Given this list of marker genes AGO4, MIR451A, CDH11, TNRC6A, AGO3, MIR200C, TNRC6B, TNRC6C, AGO1, AGO2, MOV10, here is a description of the gene set: Several microRNAs are implicated in posttranscriptional regulation of CDH11 gene expression. The diagram only shows microRNAs reported to downregulate CDH11 mRNA and/or protein levels by at least 2 studies, with at least one study providing human evidence, and at least one study providing mechanistic evidence in the form of luciferase reporter assay and/or formation of the microRNA-mRNA complex. For a more detailed description of criteria for microRNA annotation please refer to Huntely et al. 2016.<br><br>The following CDH11-targeting microRNAs are strongly supported by experimental evidence and directly shown in the diagram:<br>miR-200c-3p<br>miR-451a<br><br>The following microRNAs probably target CDH11, but additional evidence is needed to directly represent them in the diagram:<br>miR-103-2-5p<br>miR-127-3p<br>miR-148-5p Reactome Pathway: Regulation of CDH11 mRNA translation by microRNAs studied in species Homo sapiens part of: Regulation of CDH11 Expression and Function